Given this list of marker genes GALNT3, CDK5R1, NTMT1, ATM, POGLUT3, TNKS, STK39, SMG1, TRIM6, AURKA, RAF1, PRKCE (protein kinase C epsilon), NEK6, EGFR, TTBK2, ROCK1, PRKD2, STOX1 (storkhead box 1), POGLUT2, CREBL2, RIPK1, RPS6KB1, GALNT4, GALNT1, ERCC6 (NCBI Gene Id 282965), PCK1, NT5DC2, BRSK1, PKD1, TNNI3K, RASSF2, MAP3K10, ERN1 (endoplasmic reticulum to nucleus signaling 1), TBK1, NSD1, MAD2L2, CDK2, TTBK1, SPRY2, CLSPN, MAPK8, CNOT9, PTEN, PDK3, IRGM, GALNT16, TLK2, PLK1, MBOAT4, PRKACA, OSM, GALNT2, MKNK1, TENM1, PFN2 (profilin 2), NLRP2B, TGFBR1, PIKFYVE, PDCD10 (NCBI Gene Id 9226), IKBKB, GSK3B, HIPK2 (NCBI Gene Id 653052), HIPK3, IFNG, STK4, ULK1, IL6, TOP1, AKT1, IL11, SRPK2, UHMK1, POGLUT1, CDK1, MAP2K2, PRKX, LMTK2, CNKSR3, PRKDC, PRKCD, MGAT5B, PLK2, MORC3, GADD45A, LIF, PAQR3, GALNT13, PRKD1, DMTN, BRAF, MAP4K1, ARAF, MARK2 (NCBI Gene Id 2011), here is a description of the gene set: studied in species Homo sapiens Human Gene Set: GOBP_PEPTIDYL_SERINE_MODIFICATION The modification of peptidyl-serine.